The following is a description of a gene set: Human Gene Set: GSE2770_UNTREATED_VS_TGFB_AND_IL4_TREATED_ACT_CD4_TCELL_4H_DN Th1 and Th2 cells arise from a common precursor cell in response to triggering through the TCR and cytokine receptors for IL-12 or IL-4. This leads to activation of complex signaling pathways, which are not known in detail. Disturbances in the balance between type 1 and type 2 responses can lead to certain immune-mediated diseases. Thus, it is important to understand how Th1 and Th2 cells are generated. To clarify the mechanisms as to how IL-12 and IL-4 induce Th1 and Th2 differentiation and how TGF-beta can inhibit this process, we have used oligonucleotide arrays to examine the early polarization of Th1 and Th2 cells in the presence and absence of TGF-beta after 0, 2, 6 and 48 hours of polarization. studied in species Homo sapiens from publication Lund R, Aittokallio T, Nevalainen O, Lahesmaa R (PMID 14607935) Genes down-regulated in CD4 T cells: untreated (0h) versus activated by anti-CD3 and anti-CD28 and then stimulated by TGFB1 and IL4 (6h)., and this is the list of marker genes: CMTM3, C1QTNF6, ASZ1, DGKI, CSF1R, CDK5RAP3, CRYZ, DBF4, C2CD4C, CCDC38, GRK2, BAG5, CCNI, ADORA2B, IHO1 (NCBI Gene Id 339834), DBR1, AKAP5, CISD1, ANKRD2, BAZ2A, BGN, DLG5, CREB3L3, APOC2, B3GNT9, GPRASP3, CHIC2 (NCBI Gene Id 26511), TSPOAP1, ABTB1 (ankyrin repeat and BTB domain containing 1), AMIGO1, CCDC110, CAPRIN1, CDH8, MIA2, ATP6V0C, ACBD4, DAZL, CHRNA5, NAXE, ALG12, CBY1, CEP152, ATP6V1A, COASY, ATP6V0E1, CPSF4L, ADAT1, CEACAM19, CELA1, BEX1, CRMP1, COL6A6, CEP57, CAMTA1, ANKS6, CCDC61, COX16, CNTN4, CDS1, ALDH6A1 (aldehyde dehydrogenase 6 family member A1), AMPH, CORO6, CNPY4, CCDC125, CIDEC, BRAF (B-Raf proto-oncogene, serine/threonine kinase), DCAF15, BOLA1, COIL, BMPER, BAP1, CCDC33, ARMCX1, ALG10B, CHURC1, ARF4, CYBB, CHD3, ACTBL2, COX4I1, PRRC2B, ATF2, ACSM2A, DCAF10, ANKRD33B, ALDOC, CARD6, CTBP2, CETN2, CCNF, ARFGEF2, COMMD2, CAMSAP2, DMRTA2, CORO1B, AGAP1, DERL1, BZW1, FAM222A, CNTNAP4, CCND1, CHRM1, CDH11, C2orf49, CYTH4, ACLY, ACTN2, DIO1, DLG4, ABCD2, ANKS3, BMP15, B4GALNT1, CALHM3, DBNDD1, ADAM30, ATG2B, ADAMTS12, CCL17, CD6, AIPL1, DPY19L4, BBS1, BSCL2, AQP11, BTBD2, CES4A, DST, DIDO1, CCND2